The following is a description of a gene set: from publication Chen Y, Wang X (PMID 31504780) Genes predicted to be targets of miRBase v22 microRNA mmu_miR_377_3p in miRDB v6.0 with MirTarget v4 prediction scores > 80 (high confidence targets). Mouse Gene Set: MIR_377_3P studied in species Mus musculus, and this is the list of marker genes: Cartpt, Magel2, Aqp4, Slc6a3, Rbm18 (NCBI Gene Id 99170), P2ry10, Aida, Septin2, Slc49a4, Ets1, Sult1b1, D16Ertd472e, Irx2, Zfp36l1, Pdk4, Kcnb1, Ptprb, Slc6a19, Armc8, Wdr6, Exosc1, Zfp148, Zfp655, Hax1, Sh3bgrl2, Camta1, Mip, Hmox1 (NCBI Gene Id 27970), Syt11, Calcr, Grsf1, Arid1a, Btg3, Nceh1, Ubp1 (upstream binding protein 1), Larp4, Gspt2, Negr1, Cftr, Agl, Osgin2, Abraxas2, Atxn7l1, Ilrun, Lamc1, Plcb1, Zfp462, H2-M10.3, Pvr, Larp4b, Cep43, Nkain2, Setbp1 (NCBI Gene Id 93678), Tmx1, Limd1, Rasa1, Gcnt3, Tsnax, Pkia, Itprid2, Sgcb, Pum2, Sumf1, Sh2b1, Pus10, Il1rn, Atl2, Nhsl1, Dnm3, Zfp619, Dnajc19, Mcub, Trp63, Sec61a2, Snrk, Hoxa1, Hycc2, Rnf38, Zbtb26, Inka2, Fmo9, Copg2, Adamts9 (NCBI Gene Id 69070), Ncoa7, Dlgap2, Cacna2d1, Spock2 (sparc/osteonectin, cwcv and kazal-like domains proteoglycan 2), Jag1, Stox2, Nab1, Alms1, Ocrl, Jmy, Mttp, Bend3, Tmem19, Ubxn10, Snapc1, Lrp8, Stk35, Rbms1, Pitx2, Dcp1a, Tasor, Apon, Zmym4, Trio, Ppp3r1, Hexim1, Cdkn1b, Noa1, Rbm41, Cul1, Lefty2, Scn8a, Cnot6, Zscan26, Cyp2b23, Naa11, Ociad2, Fhip2b, Mtmr1, Thsd7a, Arid4b, Prl6a1, Arpp21, Gls (glutaminase), Dnajc6, Ipo5, Ube2d2a, Map4k5, Ttll7, Prrg3, Btrc, Dnajb9 (NCBI Gene Id 27362), Trip12, Pcf11 (NCBI Gene Id 97363), Csrnp3, Wdr77, Gk2, Fnbp1l, Grk6, Prkcz, Kansl1l, Cdon, Npsr1, Ube2h, Acvr2a, Fam53c, Pnrc2, Chuk, Tmprss15, Klhl24, Shh, Zfp704, Ide, Dcbld1, Gopc, Dlg2, Mybl1, Kcnj8, Fbxo30, Nt5c3b, Kif3c, Unc80, Yes1, Gvin3, Pfkfb2, Eif4a2, Slc11a2, Phf6, Rsbn1, Gabra1, Cenpv, Ptgr3, Strn4, Tanc2, Nova1, Zbtb4, Jakmip2, Tspyl5, Bcl2l1, Rnf182 (NCBI Gene Id 328234), Baz2a, Map3k8, Itm2a, Dph2, Pcdh10, Il22ra2, Smarca4, Dclk1, B230219D22Rik, Slc17a8, Mga, Ttf1, Nts, Serac1, Fchsd2, Nr6a1, Tapt1 (transmembrane anterior posterior transformation 1), Slc4a10, Lmx1a